The following is a description of a gene set: Human Gene Set: GSE17322_CD103_POS_VS_CD11B_HIGH_LUNG_DC_UP Genes up-regulated in lung dendritic cells: CD103+ versus CD11b high. from publication Edelson BT, KC W, Juang R, Kohyama M, Benoit LA, Klekotka PA, Moon C, Albring JC, Ise W, Michael DG, Bhattacharya D, Stappenbeck TS, Holtzman MJ, Sung SS, Murphy TL, Hildner K, Murphy KM (PMID 20351058) species: Homo sapiens Mouse lung CD11c+ dendritic cells are composed of 2 major DC subsets, the CD103+CD11b-low/intermediate DC (CD103+ DC) and the CD11b-highCD103- DC (CD11b-high DC). These 2 subsets are functionally distinct. Comparison of their functions showed CD103+ DC Microarray analysis was performed to compare the gene expression profiles of the 2 lung DC subsets in naïve mice., and this is the list of marker genes: RGS2, CCNYL1, BTBD6, MTMR12, PLEC, MPG, DAZAP2, RAB5A, RGS19, CTNNA1, PWWP2A, UBE2L3, SLC39A13, ZBTB33, SLC35B2, IER3, ZFAND6, RNF24, RAB13, NAGK, LTB, SAE1, ZMYM3, CALM1, ZNF29P, SGO2, RFC2, PLEKHG5, IKBIP, LRRC8C, EIF4E2, GLIS2, CALM2, ID2, HPCAL1, BLVRB, PDLIM2, SELENOH, UTRN, ENSG00000284691, ZFYVE21, SPIN4, YWHAH, PLA2G7, SLC46A2, DAPK1, CLEC4F, FERRY3, LSP1, PHTF2, TMEM19, SUMO3, CTSH, AKT1, TGFBR2, HSPBAP1, PPP1R16A, ENTPD4, PRMT2 (protein arginine methyltransferase 2), IL1RAP, SMIM14, RARS2, FCER1A, EXO5, SLAMF8, FGD2, AP3S1, KIFBP, CSF2RB, CAPZB, RAB7A, HSPB1, ZNF765, AHNAK, GALNT1, FRYL, BCL7C, PGAP2, ARHGAP45, DUSP16, DNAAF9, TAPT1, TYROBP, CRACDL, WDR5B, ZYX, RYBP, H4C3, CYTH2, MGAT4A, SNX8, KLHL22, RBPJ, SSR1, CALR (calreticulin), BCOR (BCL6 corepressor), SNAI3, RBX1, DSTN, REEP5, STRADA, NPC2, KIFC2, PLPP3, EEIG2, MAGT1, MANF, KMT2E, ZNF766, LRCH3 (leucine rich repeats and calponin homology domain containing 3), FRG1BP, FCER2, NRBP2, TNNI2, KCNK6, IDH2, CD200R1, PIP4K2A, PTPRA, RPN1, PDIA3, TLR10, NTAN1, LATS2, RNASE6, FLVCR2, DEGS1, PPP6R2, LIPA, MICAL1, CYB5R1, TET2, RIMS3, RGL2 (ral guanine nucleotide dissociation stimulator like 2), DOCK10, ZMYM6 (zinc finger MYM-type containing 6), NFKBIE, GSTT1, EXOC8, PDIA6, SEC24B-AS1, HLA-DPA1, CALM3, HLX, SDF2L1, ZNF567, ATP1B1, TSC22D4, TVP23A, TAX1BP3, ZNF627, SOCS6, SPCS3, ZNF710, ZBTB24 (NCBI Gene Id 9841), CCDC107 (NCBI Gene Id 203260), GGT5, TMED5, DHTKD1, MAPK1IP1L (mitogen-activated protein kinase 1 interacting protein 1 like), NCAPH, CD209, PRR13, LGALS3, CASKIN1 (CASK interacting protein 1), C1QB, TRIM36, CIBAR1, ZWILCH, RAD51AP1, HSPA13, GLMP, LIMS1, FAM177A1, CMTM6, MYL6, PTBP3, ZNF77, CYBA, TMED10, ZNF267, CYB5R3, ZFP36L1, STARD4, ARPC1B, KDM3A, SYNGR2, C2orf80, RGS12, SLC25A24, PPDPF, TXN, ZNF846, CLOCK, UFC1, ACP5 (acid phosphatase 5, tartrate resistant)